Given this list of marker genes CFAP52, CFAP276, RIBC1, TEKT1, CFAP68, SPAG8, CFAP90, SPACA9 (NCBI Gene Id 11092), CFAP144, SPMIP8, PIERCE1 (piercer of microtubule wall 1), CFAP100, CFAP206 (NCBI Gene Id 154313), SPMIP6, CFAP126, TEKT5, CFAP107, SPMIP9, EFHC1, PACRG (parkin coregulated), TEKT2, EFCAB6, TEKT3, PIERCE2, RIBC2, SPMIP10, CIMIP2A, CIMIP2C, MNS1, CFAP95, SAXO4, CFAP20, CFAP141, EFHB, ENKUR, CFAP45, CFAP53, NME7, CFAP161, TEKTIP1, DUSP21, CFAP73, TSSK6, EFHC2 (NCBI Gene Id 80258), CFAP77, CFAP210, SPMIP11, TEKTL1, TEKT4, here is a description of the gene set: species: Homo sapiens A cellular anatomical entity that is part of an axoneme consisting of a doublet microtubule. Human Gene Set: GOCC_AXONEMAL_DOUBLET_MICROTUBULE